The following is a description of a gene set: part of: Deubiquitination electronically inferred by orthology from the curated human pathway This event has been computationally inferred from an event that has been demonstrated in another species.<p>The inference is based on the homology mapping from PANTHER. Briefly, reactions for which all involved PhysicalEntities (in input, output and catalyst) have a mapped orthologue/paralogue (for complexes at least 75% of components must have a mapping) are inferred to the other species. species: Mus musculus Reactome Pathway: Ovarian tumor domain proteases, and this is the list of marker genes: Ube2d1, Ubb, Esr1, Rnf128, Otud3 (NCBI Gene Id 73162), Cdk1, Tnfaip3, Vcp, Vcpip1, Rps27a, Otub1, Tnip3, Otud7a, Traf3, Trp53 (NCBI Gene Id 22059), Tnip1